The following is a description of a gene set: We identified Pparg as a major orchestrator of the phenotype of adipose-tissue resident regulatory T cells (VAT Tregs). To establish the role of Pparg in shaping the VAT Tregs gene profile and cell dynamics, Tregs from lymph nodes and visceral adipose tissue of mice sufficient and deficient of Pparg expression in Tregs were double sorted for microarray analysis. from publication Cipolletta D, Feuerer M, Li A, Kamei N, Lee J, Shoelson SE, Benoist C, Mathis D (PMID 22722857) species: Homo sapiens Human Gene Set: GSE37532_VISCERAL_ADIPOSE_TISSUE_VS_LN_DERIVED_TCONV_CD4_TCELL_UP Genes up-regulated in T conv from aged mice: visceral adipose tissue versus lymph node., and this is the list of marker genes: DNASE2B (NCBI Gene Id 58511), CHRNG, BTN1A1, ANXA2 (NCBI Gene Id 792), ICAM5, KCTD14, ERMP1, TRIM29, CDKN2A, KRT9, CENPH, FCRL6, EIF1, ACTG1, SURF6, PKD2, SLC27A2, ODC1, FREM1 (NCBI Gene Id 158326), KLK4, NOP56, TMTC1, MIR335, SUGP2, SYCE2, GLUL (glutamate-ammonia ligase), MAMSTR, MRPS5, GPR158, EPHA4, JPH2, MIR135B, KRTAP6-1, VAV1, HTATIP2, KCNS3, ATP6V1E1, SLC37A3, TGM2, TOGARAM2, FGL1, EIF2AK4, PRIM2, BLVRA, GKN1, DGAT1, TRPC7, IDO1, GPRC6A, PDE1A, CHST15, FUT4, CCDC85A, MN1, CTH, PDZD2, P4HB, SCN3B, TNP2, LRRC19, IGLL1 (immunoglobulin lambda like polypeptide 1), SNORA75, ATP5F1C, MOGAT1, FOXN4, VASH2, CD70, CDT1, MIR301B, MYF6, ATP2A2, ARPC1A, SEPTIN12, ZIC1, PVT1, PTGER2, AQP1 (NCBI Gene Id 358), PBX4, ATP5F1A, CRNN, TRAP1, LMO3, PID1, STRIP1, PROK1, CPT1A, EMX1, FZD6, PTPN20, PLIN2, KLK10, PDE10A, TIGIT, GLIS3, WNT2, SNORA20, MGMT, ACER1, MAEL, CD80, PDCD6, DYDC1, LCN8, KIRREL1, TMPRSS11E, CLDN23, TANGO6, GSTO1, SDF4, GOSR2, TSBP1, CFAP144P1, GJA10, MGAT5, TXNDC2, SIPA1L1, TAP2, STAT3, SPHKAP, MPZL2, TMPRSS11D, MGAT4C, RPL7A, PRM1, SNCA, SLC43A1, CXCR6, B3GALNT1